The following is a description of a gene set: Cobalamin (Cbl, vitamin B12) is a nutrient essential for normal functioning of the brain and nervous system and for the formation of blood. Cbl-dependent methionine synthase (MTR) is required for conversion of 5-methyltetrahydrofolate (metTHF) to tetrahydrofolate (THF), in addition to its role in conversion of homocysteine to methionine. In Cbl deficiency, and in inborn errors of Cbl metabolism that affect function of methionine synthase, inability to regenerate THF from metTHF results in decreased function of folate-dependent reactions that are involved in 2 steps of purine biosynthesis and thymidylate synthesis. Cbl deficiency results in hyperhomocysteinemia (due to defects in the conversion of homocysteine to methionine which requires Cbl as a cofactor) and increased levels of methylmalonic acid (MMA). Methionine is used in myelin production, protein, neurotransmitter, fatty acid and phospholipid production and DNA methylation. Symptoms of Cbl deficiency are bone marrow promegaloblastosis (megaloblastic anemia) due to the inhibition of DNA synthesis (specifically purines and thymidine) and neurological symptoms. The defective genes involved in Cbl deficiencies are described below (Froese & Gravel 2010, Nielsen et al. 2012, Whitehead 2006, Watkins & Rosenblatt 2011, Fowler 1998). part of: Defects in vitamin and cofactor metabolism Reactome Pathway: Defects in cobalamin (B12) metabolism studied in species Homo sapiens, and this is the list of marker genes: MMUT, MMADHC, CD320, MMAA, LMBRD1, MMAB, TCN2, ABCD4, AMN, MTR, CBLIF, CUBN, MMACHC, MTRR